Given this list of marker genes Cps1, Aacs, Acsl1 (NCBI Gene Id 56355), Ass1, Dgat2, here is a description of the gene set: Any process that results in a change in state or activity of a cell or an organism (in terms of movement, secretion, enzyme production, gene expression, etc.) as a result of an oleic acid stimulus. species: Mus musculus Mouse Gene Set: GOBP_RESPONSE_TO_OLEIC_ACID